The following is a description of a gene set: species: Homo sapiens from publication Baker DA, Barth J, Chang R, Obeid LM, Gilkeson GS (PMID 20644167) Human Gene Set: GSE20152_SPHK1_KO_VS_HTNFA_OVEREXPRESS_ANKLE_UP The study analyzes analyzes gene expression changes in the ankle joint in mouse TNFa overexpression models with or without sphingosine kinase 1 activity. SphK1 is a sphingolipid enzyme that converts sphingosine to bioactive sphingosine-1-phosphate (S1P). Recent data suggest a potential relationship between SphK1 and TNFα and have implicated SphK1/S1P in the development and progression of inflammation. Here we further study the relationship of TNFα and SphK1 using an in vivo model. Transgenic hTNFα mice, which develop a spontaneous arthritis (limited to paws) at 20 weeks, were crossed with SphK1 activity null mice (SphK1-/-) to study the development of inflammatory arthritis in the functional absence of SphK1. Results show that hTNF/SphK1-/- have significantly less severity and progression of arthritis and bone erosions as measured through micro-CT images. Additionally, less COX-2 protein, mTNFα transcript levels and fewer Th 17 cells were detected in the joints of hTNF/SphK1-/- compared to hTNF/SphK1+/+ mice. Microarray analysis of the ankle joint showed that hTNF/SphK1-/- mice have increased transcript levels of IL-6 and SOCS3 compared to hTNF/SphK1+/+ mice. Finally, fewer mature osteoclasts were detected in the ankle joints of hTNF/SphK1-/- mice compared to hTNF/SphK1+/+ mice. These data show that SphK1 plays a role in hTNFα induced inflammatory arthritis, potentially through a novel pathway involving IL-6 and SOCS3. Genes up-regulated in ankle joints: SPHK1 versus wildtype over-expressing TNF., and this is the list of marker genes: ITK, NDE1, RGS12, DNAJB2, MYH14, VEZT, SEMG1, SAMD14, ATP2A2, AVL9, ZNF706, PATJ, POU3F4, CYP11B1, GPR171, EFHD2, LTN1, GATAD2A, GJA3, EPHA7, PHLDA2, TMEM268, APOBR, SERPINA10, GNA12, DUSP6, MAP3K3, RASGRF1 (Ras protein specific guanine nucleotide releasing factor 1), HTN3, FRS2, DMWD, TTLL7, TAFAZZIN, CXADR, TCF7, KCTD13, JUND, ALG9, TFG, FAM118A, MICAL3, CDC42SE1, CYP4B1, RALGAPB, GDF10, RGS17, ACVR1B, PAQR3, MAPK8IP3, RAPGEFL1, SACS, PKD1P6, ASPH, RP2, CDH18, GUSBP14, PPP2R5B, RTF2, SYNGR3, DCLK2, MTHFD2, CHMP6, KCNJ13, PKD1P1, YOD1, LRRC1, SETD3, MNS1, PRR11, PEA15, PICALM, AIM2, RNASEH2B, ZNF611, SVIL, MICA, ZNF154, C11orf58, SAT1, TMEM140, BLZF1, SYP, ASL, RDH11, SEC63, SLC44A1, MTCL2, KYAT3, CASP9, DDX39B, EMP2, ZNF587, ARHGAP17, CLCN6, CBX4, NVL, DHX9-AS1, STATH, DBT, LPIN1, SLC35F2, SALL1, OGFOD1, CCL22, ZYX, ICOSLG, PDLIM7, RPE65, RPS13, RAB15, DICER1, DDX3Y, RSL24D1, TMEM184B, CHRNA10, SMG7, LRP8, CFLAR, ROCK2, MYCL, PANK3, GOT1, TSPAN9, REPS1, SERPINB2, NBAS, HSD17B3, PDK4 (NCBI Gene Id 5166), BPY2, YAP1, ANKRD55, SH2B3, RUNX1, SCIN, KRBOX4, HUNK, NISCH (NCBI Gene Id 11188), YTHDC2, SRSF11, DGKZ, TMED7, SLC7A8, KLC1 (NCBI Gene Id 3831), PGF, BAZ1A, PPP4R3B, EYA1, USP6NL, CFTR, PDLIM1, FADS1, SLC22A13, NPIPA1, ALDH3B1, SQLE, YWHAH, POU6F1, CBX6, FERMT2, NOX4, SLC35E1, VPS54, MTHFD2L, SH3GL1, CCZ1B, ADAM29, NECTIN2, INPP5E, RORA, CIAO2B, BEX1, SCN3A, PTPN7, IMPA1, RYR1, MMD, KCTD15, MARCKSL1, EFEMP1 (NCBI Gene Id 399564), MAPKBP1, CAVIN1, HPS5 (NCBI Gene Id 246309), ACYP1, ELMO3, MLF2, MTRF1L, FHOD1, MYRIP, ROBO3, MYH1, FRMPD1, DBF4B, ZNF22, ZFHX4, KIF21B, NOTCH4, DNAH3